Given this list of marker genes Tpm3 (tropomyosin 3, gamma), Mafb, Tgfbi, F13a1, Hp, Saa3, Vsir, Ccr1, Wfdc17, Srgn, Ctsd, Krtcap2, Ctsl, Ifitm2, Gda, Calr, Lilrb4b, Tpd52, Hif1a, Il4ra, Ccr2, Ifitm1, Socs3, Morf4l2, Llph, F10, Tspo, here is a description of the gene set: species: Mus musculus Cytokines mediate cell-cell communication in the immune system and represent important therapeutic targets. A myriad of studies have highlighted their central role in immune function, yet we lack a global view of the cellular responses of each immune cell type to each cytokine. To address this gap, the authors created the Immune Dictionary, a compendium of single-cell transcriptomic profiles of more than 17 immune cell types in response to each of 86 cytokines (>1,400 cytokine-cell type combinations) in mouse lymph nodes in vivo. A cytokine-centric view of the dictionary revealed that most cytokines induce highly cell-type-specific responses. For example, the inflammatory cytokine interleukin-1β induces distinct gene programmes in almost every cell type. A cell-type-centric view of the dictionary identified more than 66 cytokine-driven cellular polarization states across immune cell types, including previously uncharacterized states such as an interleukin-18-induced polyfunctional natural killer cell state. Mouse Gene Set: CUI_MONOCYTE_IL10_RESPONSE_UP from publication Cui A, Huang T, Li S, Ma A, Pérez JL, Sander C, Keskin DB, Wu CJ, Fraenkel E, Hacohen N (PMID 38057668) Genes positively differentially expressed in cell type: Monocyte upon treatment with cytokine: IL-10 in mouse lymph nodes in vivo.